The following is a description of a gene set: Mitochondrial autophagy in mammalian cells was first observed in glucagon-stimulated hepatocytes. The mechanisms of mitophagy in mammalian cells remain unclear. Oxidative stress and mPTP are involved in the initiation of mitophagy. Receptor mediated mitophagy links both cellular differentiation signals and markers of mitochondrial function to LC3 and Atg32, scaffold proteins important for cargo selection and autophagosome formation. These scaffold proteins recruit other autophagy proteins to form the autophagosomes; destroying and recycling mitochondria.<br>Mitophagy receptors have to meet at least three criteria: 1) it must be mitochondrially localized, 2) it must interact with LC3/ ATG8 in response to a certain stimulus, and 3) it must have a consensus sequence of W/F/YxxL/I known as the LIR motif. This tetrapeptide sequence is present in several Atg8 or LC3-binding partners that are important for selective autophagy.<br><br>FUNDC1-mediated mitophagy is inhibited by its phosphorylation at the Tyr 18 position in the LIR motif by Src kinase under normoxia conditions. Upon hypoxia stimulation, Src is inactivated and FUNDC1 at the Tyr 18 position is dephosphorylated by an unknown phosphatase, resulting in an increase of the interaction between FUNDC1 and LC3-II, leading to the selective incorporation and autophagic removal of the mitochondrion.<br><br>The outer mitochondrial membrane protein NIX/BNIP3L is involved in autophagic turnover of mitochondria in reticulocytes, a process essential for red blood cell maturation. The mechanism through which NIX senses signals from red blood cell differentiation is unclear. Phosphorylation of serine residues 17 and 24 flanking the BNIP3 LIR promotes binding to specific LC3 family members LC3B and GATE-16 and increases lysosomal destruction of mitochondria. Reactome Pathway: Receptor Mediated Mitophagy species: Homo sapiens part of: Mitophagy, and this is the list of marker genes: ATG12, SRC, FUNDC1, MAP1LC3A (microtubule associated protein 1 light chain 3 alpha), ULK1, ATG5, MAP1LC3B, CSNK2A2, CSNK2B, CSNK2A1, PGAM5